The following is a description of a gene set: from publication Motenko H, Neuhauser SB, O'Keefe M, Richardson JE (PMID 26092688) studied in species Mus musculus Mouse Gene Set: MP_INCREASED_SKIN_PAPILLOMA_INCIDENCE Mouse genes annotated to increased skin papilloma incidence (MP:0002051) retrieved from the Mouse Genome Informatics database via MouseMine, and this is the list of marker genes: Trp53, Paqr3, Tnfrsf1b, Tnfrsf1a, Hras, Gstp2, Fgfr2, Cdsn, Grhl3, Kras, Egr1, Chuk, Cd34, Ptgs2, Sfn, Atp2a2, Krt14, Smad4, Rad9a, Pten, Cyld, Braf, Aurkb, Krt9, Atf2, Mapkapk5, Cebpa, Cdk11b, Ppard, Atp2c1, Odc1, Errfi1, Gstp1, Prkch, Prkca